The following is a description of a gene set: species: Homo sapiens Catalysis of the reaction: phosphatidylcholine + H2O = 1-acylglycerophosphocholine + a carboxylate. This reaction does not require Ca2+. Human Gene Set: GOMF_CALCIUM_INDEPENDENT_PHOSPHOLIPASE_A2_ACTIVITY, and this is the list of marker genes: PLA2G15, PLB1, PLA2G5, PRDX6 (NCBI Gene Id 9588), PLA2G7, PNPLA8, PLA2G4A, PLA2G4C, PLA2G6